Given this list of marker genes Ovol1, Npr2, Nanos2, Pdik1l, Dusp1, Rad1, Prkaca, Chfr, Knl1, Mos, Rps6ka2, Pkmyt1, Lif, Zfy2, Zwint, Fbxo5, Prkacb, Osm, Hormad1, Trip13, Fbxo43, Nppc, Stk35, Grb14 (NCBI Gene Id 99012), Dmrt1, Ttk, here is a description of the gene set: Any process that stops, prevents or reduces the rate or extent of progression through the meiotic cell cycle. studied in species Mus musculus Mouse Gene Set: GOBP_NEGATIVE_REGULATION_OF_MEIOTIC_CELL_CYCLE